Given this list of marker genes Lipf, Pten, Insl6, Gm10136, Gm50266, Gm8412, Cd274, Smarca2, Uhrf2, Brd10, Sgms1os1, Minpp1, Gm36419, A1cf, Acta2, Rnls, Asah2, Jak2, Prkg1, Mir3970, Pum3, Sgms1, Ifit1, Gm26046, Gm9895, 4933413C19Rik, Slc16a12, Fas, Gm18293, Gm6788, Gm20616, Gm35781, Papss2, Kcnv2, Gm3621, Lipo2, Gm9563, Gm36043, Lipn, 2610016A17Rik, Ifit2, Cstf2t, Gm19241, Dmrt2, Cdc37l1, Gm19724, Mir1950 (microRNA 1950), Gm29946, Gm8988, Rfx3, Gm7237, Rpl31-ps20, Mlana, Gm5517, Rpl9-ps6, Vldlr, Gm24782, Lipo3, Ifit3, Gm19755, Ifit1bl2, Rcl1, Plpp6, Glis3, Mir107, Lipo4, 4931403E22Rik, A930007I19Rik, Gm50113, D930032P07Rik, Stambpl1, Gm8825, Gm8978, Gm18380, Atad1, Rln1, Gm5822, Gm36860, Kif20b, Ric1 (RAB6A GEF complex partner 1), Lipk, Gm31300, 1700018L02Rik, Gm17885, Il33, Mir101b, Ifit3b, Ppp1r2-ps3, Rps15a-ps2, Gm8980, Gm25176, Gm22082, Ranbp6, Gm5519, Ak3, Gm38616, Ermp1, Lipa, Gm50233, Dkk1, Spata6l, Gm23095, Plgrkt, Pdcd1lg2, Trpd52l3, 1700048O14Rik, Gm34808, Gm5518, Ankrd22, Gldc, Lipo1, Gm35554 (predicted gene, 35554), Gm815, Lipm, Ch25h, Mbl2, Slc1a1, Pank1 (pantothenate kinase 1, NCBI Gene Id 78262), Ifit1bl1, Cnn2-ps, Gm18425, Lipo5, here is a description of the gene set: Mouse Gene Set: chr19C1 species: Mus musculus